The following is a description of a gene set: studied in species Mus musculus Mouse Gene Set: GOBP_VACUOLAR_TRANSPORT The directed movement of substances into, out of or within a vacuole., and this is the list of marker genes: Stx7, Ap3d1 (adaptor-related protein complex 3, delta 1 subunit), Ndfip1, Clec16a, Pink1, Vps51, Sort1, Vps41, Trak1, Arl8b, Clu, Snapin, Chmp1a, Ap1g1, Slc30a4, Lamp1, Vps54, Vps29, Lipa, Stx8, Ubxn6, Vps11, Lyst, Tmem50a, Vti1b, Hook1, Mon1b, Vps37b, Vipas39, Gprasp1, Leprotl1, Snx27, Leprot, Ankfy1, Gnptab, Chmp2b, Slc17a9, Slc30a2, Vps39, Grn, Lyset, Mon1a, Vcp, Gak, Igf2r, Npc1, Sqstm1, Snf8, Rufy4, Ncoa4, Atp13a2, Sptbn5, Bin1, Vps4b, Vps13a, Fhip1b, Prkn, Ndp, Plekhm2 (pleckstrin homology domain containing, family M (with RUN domain) member 2), Rbsn, Hgsnat, Hspa1a, Vps37d, Hook3, Ptpn23, Vps16, Atp6v0d1, Mgrn1, Atp6v0d2, Vps36, Dtx3l, Vta1, Tmem106b, Tpcn2, Lrp1 (low density lipoprotein receptor-related protein 1), Chmp3, Ap1g2, Pik3r4, Tsg101, Ap4m1, Chmp2a, Pcdhga3, Cln3, Rab7, Vps25, Rhob, Gga3 (NCBI Gene Id 260302), M6pr, Chmp1b2, Chmp7, Vps8, Rab34, Snx16, Aktip, Slc48a1, Pik3c3, Psap, Mtm1, Gcc2, Ap3s1, Nedd4, Ehd3, Kif13a, Vps35, Hook2, Plekhm1, Tmem50b, Smurf1, Chmp6, Tgfbrap1, Ap3b1, Hspa8, Scyl2, Atg14, Mfsd1, Rab12, Stam, Vps37c, Zfyve16, Laptm5, Vps53, Vps33a, Vps13c, Lamp2, Slc30a3, Mvb12a, Pcsk9, Arf1, Uevld, Irgm2, Vps4a, Als2, Lhcgr, C9orf72, Rab7b, Chmp1b, Plekhf2, Hgs, Vps28, Chmp4b, Cdx2, Epg5, Igtp, Vps13d (vacuolar protein sorting 13D), Vps52, Ccdc91, Vps37a, Scarb2, Plekhf1, Irgm1, Becn1, Vps18, Rilp, Chmp4c (charged multivesicular body protein 4C), Sorl1, Chmp5, Becn2, Ap3s2, Vti1a, Dennd3, Trak2